Given this list of marker genes Calm2, Fcgr3, Hmgb2, Klf2, Pycard, Pik3cd, Bin1, Pitpnm1 (NCBI Gene Id 98172), Ostf1, Sp100, Glipr2, Arhgap9 (Rho GTPase activating protein 9), Ptprcap, Myo1f, Arhgap45, Adgre5, AB124611, Tcf7, Cd96, Eif3f, H2az1, Cbl, Ltb, Entrep3, Mxd4, Tmem50a, Slfn2, Jak1, Tyrobp, Dgkz, Septin1, Zbtb20, Fos, Celf2, Cdk2ap2, Twf2, Ighm, Tm6sf1, Tsc22d3, Septin6, Ctsw, Pdcd4, Jakmip1, Fau, Cd52, Il7r, Ptpn18, H2az2, Ugcg, Prkacb, Emp3, Spn, Ubash3b, Arhgef1, Arsb, Klrb1c, Neurl3, Cd9 (NCBI Gene Id 12527), Tut4 (NCBI Gene Id 320841), Itgb1 (integrin beta 1 (fibronectin receptor beta)), Btg2, Ctdsp2, Acaa2, Evl, Ccl5, Supt4a, Srgn, Trbc1, Lsp1, Il16, Tspo (translocator protein), Ahnak, Sorl1, Limd2, Epsti1, B4galnt1, Rp9, Pfdn5, Hsd11b1, Cxcr4, Adcy7, Shisa5, Cox7a2l, Pnrc1, Itgal, Peak1, Kif21b, Zfp36l2, Tle5, Ctsd, Anxa1, Cxxc5, Fth1, Add1, Cst7, Stat4, Eef2, S100a10, Arhgef18, Tbc1d10c (NCBI Gene Id 74822), Uqcrh, Tmsb10, Cd44, Hcst, Cd27, Scamp3 (NCBI Gene Id 24045), Cd7, Cyba, Rabac1, Crip1 (NCBI Gene Id 12925), Ypel3, Pbxip1, Rnf130, Laptm5, Lgals1, Rgs2, Arhgdib, Txnip, Lasp1, Klrb1a, Ripor2, S100a6, Cdc42ep3, Abca2, Fosb, Mapre2, Zyx, Cd2, Peli1, Cd72, Abcg1, Arl4d, Vim, Pglyrp1, Sh3bgrl3, Itm2b, Gpx4 (glutathione peroxidase 4), Klrd1, Plec, Klrb1f, here is a description of the gene set: Genes negatively differentially expressed in cell type: NK cell upon treatment with cytokine: IL-12 in mouse lymph nodes in vivo. Cytokines mediate cell-cell communication in the immune system and represent important therapeutic targets. A myriad of studies have highlighted their central role in immune function, yet we lack a global view of the cellular responses of each immune cell type to each cytokine. To address this gap, the authors created the Immune Dictionary, a compendium of single-cell transcriptomic profiles of more than 17 immune cell types in response to each of 86 cytokines (>1,400 cytokine-cell type combinations) in mouse lymph nodes in vivo. A cytokine-centric view of the dictionary revealed that most cytokines induce highly cell-type-specific responses. For example, the inflammatory cytokine interleukin-1β induces distinct gene programmes in almost every cell type. A cell-type-centric view of the dictionary identified more than 66 cytokine-driven cellular polarization states across immune cell types, including previously uncharacterized states such as an interleukin-18-induced polyfunctional natural killer cell state. Mouse Gene Set: CUI_NK_CELL_IL12_RESPONSE_DN from publication Cui A, Huang T, Li S, Ma A, Pérez JL, Sander C, Keskin DB, Wu CJ, Fraenkel E, Hacohen N (PMID 38057668) studied in species Mus musculus